Given this list of marker genes CA3, PRM1, WDR1, ASB2, IRAG1, SETD2, FOS, JUNB, TAFAZZIN, TNNC1, EGR3, GPR20, PRUNE2, EGR2, VCL, IL17B, ITGB1BP2, HOXB4, DIXDC1, ANXA6, MUS81, MYL6 (NCBI Gene Id 4637), ACTN1, PHOX2B, NPAS4, CD248, STX10 (NCBI Gene Id 8677), CALD1, IER2, EGR4, SUSD1, FLNA, FOSL1, PLCB3, IGF2-AS, TPM1, ACTG2, THBS1, KCNMB1, CAP1, SCOC, PFN1, ACTR3, TGFB1I1, TNMD, SLC25A4, FOSB (NCBI Gene Id 2354), CFL1, MYH11, CNN2, EGR1, here is a description of the gene set: studied in species Homo sapiens Genes having at least one occurrence of the motif ATGCCCATATATGGWNNT in the regions spanning 4 kb centered on their transcription starting sites. This matches the SRF transcription factor binding site V$SRF_01 (v7.4 TRANSFAC). Human Gene Set: SRF_01